The following is a description of a gene set: Increased distance between the maxillary central permanent incisor tooth. Widely-spaced maxillary central incisors studied in species Homo sapiens Human Gene Set: HP_WIDELY_SPACED_MAXILLARY_CENTRAL_INCISORS, and this is the list of marker genes: ABCC9, FREM1, GATAD2B, ATRX, ALX3, RNF2, DNMT3A, STAG1, CHSY1, ANKRD11